The following is a description of a gene set: Reactome Pathway: Metabolism of carbohydrates and carbohydrate derivatives species: Homo sapiens Starches and sugars are major constituents of the human diet and the catabolism of monosaccharides, notably glucose, derived from them is an essential part of human energy metabolism. Glucose can be catabolized to pyruvate (glycolysis) and pyruvate synthesized from diverse sources can be metabolized to form glucose (gluconeogenesis). Glucose can be polymerized to form glycogen under conditions of glucose excess (glycogen synthesis), and glycogen can be broken down to glucose in response to stress or starvation (glycogenolysis). Other monosaccharides prominent in the diet, fructose and galactose, can be converted to glucose. The disaccharide lactose, the major carbohydrate in breast milk, is synthesized in the lactating mammary gland. The pentose phosphate pathway allows the synthesis of diverse monosaccharides from glucose including the pentose ribose-5-phosphate and the regulatory molecule xylulose-5-phosphate, as well as the generation of reducing equivalents for biosynthetic processes. Glycosaminoglycan metabolism and xylulose-5-phosphate synthesis from glucuronate are also annotated as parts of carbohydrate metabolism.<p>The digestion of dietary starch and sugars and the uptake of the resulting monosaccharides into the circulation from the small intestine are annotated as parts of the “Digestion and absorption” pathway. part of: Metabolism, and this is the list of marker genes: B3GALT2, PHKG2, ABCC5, RBKS, PCK2, PGK1, PRPS1, ST3GAL6, EXTL3, BGN (NCBI Gene Id 633), HPSE, ST6GALNAC6, HPSE2, B3GAT2, B3GAT1, B3GNT2, SEH1L, CHST12, IDS, SLC35B3, MAN2B2, UBB, SLC37A1, GCK, G6PC1 (glucose-6-phosphatase catalytic subunit 1), SORD, GLB1L2, CHST2, SLC26A2, HS6ST1, NUP153, FUT4, LYVE1, HS3ST1, HS3ST3A1, CHST3, POM121C, NUP155, SDC2, ENO1, CHST15, ENO3, GNPDA1, GLCE, PGK2, NUP50, SDC4, GALM, UST (NCBI Gene Id 10090), CHST13, DERA, CSPG4, NUP37, CHP1, CRYL1, DCN, GPI, CTSL, PYGL, GAA, HK3, B3GAT3, HS3ST3B1, GUSB, PYGB, IDUA, ST3GAL2, PKLR, NUP98, NDST2, UGP2, CSGALNACT1, PRKACB, NUP210, CHSY3, PRKACG, PRELP, UBA52 (NCBI Gene Id 7311), POM121, PHKA2, ALDOC, B4GALT2, OMD, HS3ST5, NUP188, CHSY1, RHD, SLC26A1, PGAM1, MAN2C1 (mannosidase alpha class 2C member 1), AKR1B1, B4GALT3, ENO4, FMOD, PC, RANBP2, PHKA1, NUP43, FUT2, TPI1, FBP2, RPIA, BPGM, NHLRC1, GLYCTK, PHKG1, AAAS, RPE, B4GALT4, NUP42, AKR1E2, HS2ST1, PGM1, CHST5, NUP58, NDC1, FUT7, NUP133, RHCE, B3GNT4, GCKR, CSGALNACT2, FBP1, UXS1, SLC35B2, GNPDA2, HYAL2, HS3ST6, XYLT2, ALDH1A1, PGAM2, CHST14, OGN, ALDOA, HMMR, CHST7, GYG1, G6PD, PPP2R5D, HAS1, PXYLP1, PFKFB1, KHK, FUT9, NUP54, HK1, B4GALNT2, SEC13, PRPS2, PAPSS1, SLC26A11, SHPK, CALM1, G6PC2, AGL, FUT6 (NCBI Gene Id 2528), FUT5, SDC3, NDST4, HYAL1, NUP160, PGD, CHST9 (NCBI Gene Id 83539), B4GALT6, ACAN, SLC37A2, NUP62, SLC17A5, GLB1L, AGRN, HYAL4, NUP205, ADPGK, TKT, NUP107, HAS2, PFKL, SGSH, GYS1, GYS2, HS3ST2, GPC5, LALBA (NCBI Gene Id 3906), PFKFB2, HEXB (hexosaminidase subunit beta, NCBI Gene Id 3074), CHST1, PFKM, HGSNAT, DSEL, NUP35, PFKFB3, CEMIP, ENO2, NAGLU, UBC, PPP2CA, ALDOB, PPP1R3C, B3GALT4, HS6ST2, HSPG2, CHST6, TALDO1, STAB2, KERA, EXT1, XYLT1, CHST11, GNS, FUT1, GLB1L3, PYGM, NCAN, RPEL1, HK2, B4GAT1, PFKFB4, CD44, ARSB, NDST3, B3GALT6, DCXR, PGM2L1, SLC37A4, PPP2CB, RPS27A, MAN2B1, VCAN, TPR, PRKACA, GALE, SLC35D2, CHPF2, PGLS, LUM, GPC2, SLC2A1, HS3ST4, B4GALT5, B3GNT7, PHKB, B4GALT1, BCAN, G6PC3 (glucose-6-phosphatase catalytic subunit 3), ST3GAL1, GYG2, NUP88, PRPS1L1, MANBA, SLC9A1, GALK1, GAPDHS, CSPG5, PGM2, FUT3, ST3GAL4, PCK1, NDST1, GBE1, CHPF, B4GALT7 (NCBI Gene Id 202179), SPAM1, PPP2R1A, GLB1, B3GNT3, ABO, B3GALT5, NUP93, HAS3 (NCBI Gene Id 3038), NUP214, HYAL3, HEXA, GALNS, GALT, HKDC1, ST3GAL3, NUP85, SDC1, PPP2R1B (NCBI Gene Id 5519), GPC4, AKR1A1, GPC1, PAPSS2, HS6ST3, FAM20B, EPM2A, PFKP, DSE, EXT2, GAPDH, TKFC, GPC6, XYLB, RAE1, EXTL2, PKM, B3GALT1, GPC3